The following is a description of a gene set: species: Homo sapiens Decreased cervical spine flexion due to contractures of posterior cervical muscles Human Gene Set: HP_DECREASED_CERVICAL_SPINE_FLEXION_DUE_TO_CONTRACTURES_OF_POSTERIOR_CERVICAL_MUSCLES, and this is the list of marker genes: EMD, FHL1, SYNE1, PLEC, LMNA, SYNE2, TMEM43